The following is a description of a gene set: SUMOylation of ubiquitinylation proteins Mouse Gene Set: REACTOME_SUMOYLATION_OF_UBIQUITINYLATION_PROTEINS species: Mus musculus, and this is the list of marker genes: Nup210, Pias4, Tpr, Nup88, Trim27, Nup153, Pias2, Nup107 (NCBI Gene Id 97632), Ranbp2, Mdm2, Sec13, Nup37, Seh1l, Sumo1, Nup98, Nup58, Nup50, Nup43, Nup62, Nup54, Nup133, Vhl, Aaas, Nup42, Nup93, Nup155, Pom121, Nup205, Nup85, Rae1, Pml, Ube2i, Ndc1, Pias1, Nup160, Nup35, Nup188, Nup214